The following is a description of a gene set: Human Gene Set: HP_PROXIMAL_RADIO_ULNAR_SYNOSTOSIS An abnormal osseous union (fusion) between the proximal portions of the radius and the ulna. species: Homo sapiens Proximal radio-ulnar synostosis, and this is the list of marker genes: B3GALT6, CHSY1, FGFR2, FGFR3, TWIST1, HOXA11